Given this list of marker genes EFNB2, PIAS1, MIR19A, PIEZO1, LAMB2, TGFB1, MYOG, LAMC1, MIR199A1, MIR133A1, SHH, MESP1, SOD2, OLFM2 (olfactomedin 2), HOPX, MIR19B1, MIR125B1, MAML1, MIR499A, MIR34A, MIR1-1, MIR208A, MTOR, ARRB2, NID1, MIR424, MAPK11, NOTCH2, SMARCD3, MIR206, MAPK12, LMOD3, BCL2, MAPK14, BMP4, LAMA1, MYF5, MIR204, TARBP2, MDM2, PARP2, CAMK1, BMP10, NOTCH4, ENG, KIT, TRIM32, SIRT1, EDN1, IGF1, EFEMP2, MIR18A, LAMB1, MYF6, CTH, MYLK3, MIR145, ATP11A, LAMA2, RBM24, AKAP6, SMYD1, MIR133B, NOTCH1, SETD3, MIR22, TBX1, GPER1, RBM4, SHOX2, MYOCD, ACTN3, NRG1, MYOD1, PRKD1, CAV3, MIR140, MIR21, MMP14, CYP26B1, MEF2C, WNT3A, MAMSTR, PROX1, KAT2A, here is a description of the gene set: species: Homo sapiens Any process that activates or increases the frequency, rate or extent of muscle cell differentiation. Human Gene Set: GOBP_POSITIVE_REGULATION_OF_MUSCLE_CELL_DIFFERENTIATION